The following is a description of a gene set: studied in species Mus musculus Genes predicted to be targets of miRBase v22 microRNA mmu_miR_33_5p in miRDB v6.0 with MirTarget v4 prediction scores > 80 (high confidence targets). from publication Chen Y, Wang X (PMID 31504780) Mouse Gene Set: MIR_33_5P, and this is the list of marker genes: Nt5dc1, Kcnq5, Abca1, Map3k3, Eef1a1, 2410002F23Rik, Nufip2, Phf12, Ankrd1, Hmga2, Cadps, Gca, Tsc22d2, Kcnma1, Hipk2, Ttll7, Adra2a, Rgn (NCBI Gene Id 19733), Enc1, Slc25a25, Cntn4, Crot, Ankrd44, Msrb3, Cdk6, Nipal4 (NCBI Gene Id 214112), Igsf1, En2, Epha8, Tph2 (tryptophan hydroxylase 2), Arid5b, Csmd2, Cpeb2, Zfp516 (NCBI Gene Id 84566), Homer1, Ttc28, Zfp81, Mab21l4, Plaat1, Cacna1c, Zfp281, Pdgfra, Sgcb (sarcoglycan, beta (dystrophin-associated glycoprotein)), Pi4k2a, Sntg1, Tmem86a, Rb1cc1, Cdk16, Caln1, Cntln, Cadm2, Ppp2r3a (NCBI Gene Id 319351), Pter, Dcp1a, Glcci1, Cfap58, Ebf1, Ankrd28, Arhgef2, Grm8, Snx7, Hephl1, Ywhah (NCBI Gene Id 22629), Gpcpd1, Vezt, Ahcyl1, Fbxw7, Hadhb, Tbc1d12 (TBC1D12: TBC1 domain family, member 12), Grik2, Rap2a, Slc12a5, Ctnnd1 (NCBI Gene Id 99192), Map4k4, Pim1, Rgs2, Ccnj, Rora, Pgam5, Smarca5, Mbtd1, Rps6kb1 (ribosomal protein S6 kinase, polypeptide 1), Naa15, Sec24c, Aard, Pim3, Tmem71, Cntn1, Trim2